The following is a description of a gene set: The process in which ions are transported across a membrane such that the membrane potential changes in the repolarizing direction, toward the steady state potential. For example, the repolarization during an action potential is from a positive membrane potential towards a negative resting potential. Mouse Gene Set: GOBP_MEMBRANE_REPOLARIZATION species: Mus musculus, and this is the list of marker genes: Wdr1, Dlg1 (discs large MAGUK scaffold protein 1), Kcnip2, Gja1, Snta1, Ywhae, Kcnd3, Kcnd2, Kcnj2, Kcnj5, Rnf207, Atp1b2, Kcna5, Cav3, Kcnn2, Ank2, Kcne4, Akap6, Adcy10, Cav1, Nppa, Cacna1d, Nos1ap, Akap9, Slc24a4, Atp1b1, Flna, Scn1b, Kcne2, Cacnb3, Gja5, Atp1a1, Kcne5, Kcna1, Kcnq1, Kcnh6, Cacna2d1, Scn5a, Kcne1 (NCBI Gene Id 16509), Scn4b, Kcnj8, Zmpste24 (NCBI Gene Id 230709), Scn2b (sodium channel, voltage-gated, type II, beta), Kcne3, Atp1b3, Nedd4l, Akap7, Kcnh2, Casq2, Kcnip1